The following is a description of a gene set: Human Gene Set: GOBP_POSITIVE_REGULATION_OF_FIBROBLAST_APOPTOTIC_PROCESS studied in species Homo sapiens Any process that activates or increases the frequency, rate or extent of fibroblast apoptotic process., and this is the list of marker genes: TP63, BTG1, NUPR1, STK17A, STK17B (serine/threonine kinase 17b), SFRP1, BCL2L11, PRDM11, MIR181B1, BBC3, BID